The following is a description of a gene set: Human Gene Set: HP_ABNORMAL_THALAMIC_SIZE Deviation from the normal range of size of the thalamus. Abnormal thalamic size studied in species Homo sapiens, and this is the list of marker genes: POMK, POMGNT1, POMT2, GMPPB, FKRP, SLC2A1, POMT1, GSX2, MED17, EXOC7